Given this list of marker genes NIPA1, RHAG, CSN3, CSN1S1, NIPAL4, ADD2, MAGT1, PIP, NIPA2, RHBG, LRRC8C (leucine rich repeat containing 8 VRAC subunit C), ANKH, ADD1, MMGT1, AZGP1, ADD3, CTNS, LRRC8B, LRRC8D, MRS2, NIPAL3, LRRC8A, DMTN, NIPAL2, RHCG, TUSC3 (NCBI Gene Id 7991), LRRC8E, NIPAL1, SLC66A1, here is a description of the gene set: studied in species Homo sapiens Reactome Pathway: Miscellaneous transport and binding events This section contains known transport and binding events that as of yet cannot be placed in exisiting pathways. part of: Transport of small molecules